The following is a description of a gene set: from publication Chen Y, Wang X (PMID 31504780) Mouse Gene Set: MIR_6984_3P species: Mus musculus Genes predicted to be targets of miRBase v22 microRNA mmu_miR_6984_3p in miRDB v6.0 with MirTarget v4 prediction scores > 80 (high confidence targets)., and this is the list of marker genes: Abce1, Slc2a13, Ptchd4, Itpripl1, Gpn1, Psd3, Ppp4r1, Cnot6l, Tshr, Lamtor1, Arl15, Eif3j2, Kmt5b, Zfp758, Rab14, Pcdha4, Sgip1, Bmp6, E130311K13Rik, Naa11, Fut9, Adamtsl3, Pcdha8, Asf1a, Stk26, Smg1, Stag2, Fam107b, Ube2b, Nxph2, Map3k2, Arl6ip6, Pcdha1, Plaa, Gclc, Pcdha2, Ctdspl2, Xiap, Rc3h1, Mettl21c, Wdr59, Haspin, Magi1, Mitf, Slitrk6, Kcnab3, Rpp14, Slc2a2, Itpr1, Mex3a, Sis (NCBI Gene Id 69983), Sar1a, Wdr33, Pthlh, Tmem100, Fndc3c1 (fibronectin type III domain containing 3C1), Ilf3, Pcdhac1, Rbfox1, Pum2, Evi2a, Mical3, Ppp2r3d, Pcdhac2, Ppbp, Gadl1 (glutamate decarboxylase-like 1), Fnd3c2, Pcdha9, Pcdha3, Snx24, Gda, Ttbk2, Sri, Vcp, Pcmtd1, Cul4b, Tbk1, Atp8a1, Rangap1, Cldn17, Pcdha11, Tnfaip3, Sult1c1, Slc7a13, Scfd2, Fbxo5, Celf1, Gpcpd1, B3gat2, Spry1, Chordc1, Dpyd, Oog1, Asb4, Pcdha5, Cbx3, Gbp3, Tnrc6a, Klrk1 (killer cell lectin-like receptor subfamily K, member 1), Il1r1, Eif3j1, Pcdha6 (protocadherin alpha 6), Ppp2r3c, Synm, Zfhx3, Muc15, Edc4, Gm2042, Ppp1r3g, Pcdha7, Peli1, Trim34a, Adipor1, Itsn1, Negr1, Necap1, Zfp182, Pcdha12, Gja3, Cfh, Myorg, Uevld, Slc8a1, Klf10, Cblb, Egr2, Kank2, Slc4a7, Smim13, Fbxo45, Fbxo11, Stk24 (serine/threonine kinase 24), Wnt5a, Atg5, Lyzl1, Prr16, Xk, Rora, Lrrc18, Sirt1 (sirtuin 1), Psmc3ip, Plppr5, Gtpbp4, Srr, 4933412E24Rik, Ppp3r1, Pcdha10, Ptbp2, Trappc13 (NCBI Gene Id 69905), Mtfr1, Ccser1, Btbd3, Spart, Pate6, Zc3h12c, Il13ra1 (NCBI Gene Id 16164), Ptpdc1, F9, Usp6nl, Panx3, Twsg1, Faxc, Gcn1